Given this list of marker genes MYBL2, KIF2C, PLK1, CCNB1, CENPA, H2AX, HMGN2, PTGS2, CCNA2 (NCBI Gene Id 890), CDC20, KIF11, FOXM1 (forkhead box M1), UBE2C, KIF23, CENPF, CCNF, here is a description of the gene set: Human Gene Set: LY_AGING_MIDDLE_DN from publication Ly DH, Lockhart DJ, Lerner RA, Schultz PG (PMID 10741968) Messenger RNA levels were measured in actively dividing fibroblasts isolated from young, middle-age, and old-age humans and humans with progeria, a rare genetic disorder characterized by accelerated aging. Genes whose expression is associated with age-related phenotypes and diseases were identified. The data also suggest that an underlying mechanism of the aging process involves increasing errors in the mitotic machinery of dividing cells in the postreproductive stage of life. We propose that this dysfunction leads to chromosomal pathologies that result in misregulation of genes involved in the aging process. species: Homo sapiens Genes down-regulated in fibroblasts from middle-age individuals, compared to those from the young donors.